Given this list of marker genes ZMPSTE24 (NCBI Gene Id 10269), FGFR3, F12, KCNJ6, IDS, BTNL2, SH3BP2, XPNPEP2, GNE, AHDC1, ZSWIM6, SOX9 (SRY-box transcription factor 9), HLA-DRB1, POR, FGFR2, DDRGK1, COL11A1, LMNA, here is a description of the gene set: Human Gene Set: HP_UPPER_AIRWAY_OBSTRUCTION Upper airway obstruction studied in species Homo sapiens Increased resistance to the passage of air in the upper airway.